Given this list of marker genes Man1c1, 1700104B16Rik, Col4a4, Ap1m1, Carmil1, Tmem95, Inafm1, Sergef, Bmf, Pcid2, Itgb8, Arhgef40, 1700003M07Rik, Gskip, Cimap3, Zfp653, Asb7, Ncoa5, Gadd45g, Cnnm2, Taf11, Fam216a, Ppp5c, Rasgrf2, Panx1, Ric8a, Tiam1, Jam3, Ift57, Matcap2, Atp6v1d, Kcp, Pdik1l, Hhipl1, Nudt1, Kif3b (kinesin family member 3B), Asic2, Ccdc138, St6gal2, Nfkbiz, Git1, Rsph4a, Gse1, Kcnmb3, Mfsd2a, Psen1, Shb, Tbc1d16, Impdh1, Lrfn4, 1700003E16Rik, Lrrc43, Cfap73, Brms1, Col26a1, Faah, Fbxo31, Ppp1r13l, Sgsm1, Spmip8, Smarcd3, Ssr2, Susd1, Dok7, Camk2a, Cldn9, 1700041G16Rik, Polr1f, Atp12a, 5033430I15Rik, Hsf1, Tm9sf1, Tsr1 (TSR1 20S rRNA accumulation), Ush2a, Trmt5, Pinlyp, Fzr1, Slc6a3, Pde6c, Snrnp25, Arhgap44, Macrod1, Efl1, Col4a6, Gm15934, Tmem88b, Scrn1, Churc1, Pcsk2os2, Rsad1, Syt5, Mir330, Eftud2, Nek2 (NCBI Gene Id 98226), AA386476, Gpbar1, Mrps2, Gpat3, 4931415C17Rik, Mms19, Pnma8a, Hrh2, Crocc2, Shank2, Gm10044, Mir6392, Mxd4, Dpp6, Sys1, Dnah7a, Pde4a, Cemip, Slc25a29, Fam167a, Inpp4a, Spata7, Togaram1, Akap9, Wdr90, Lgi4, Abr, Usp46, Gm3294, Sgms2, Sppl2b, 1500035N22Rik, Mir132, Clba1, Apbb1, Syn2, Aldh3b1, Gm11585, Tenm4, Psmc2, Padi1 (NCBI Gene Id 213073), Plek2, Slc25a10 (solute carrier family 25 (mitochondrial carrier, dicarboxylate transporter), member 10), Slc7a6, Mapre3, Pgap4, Rufy2, Gm16505, Arih1, Gm17249, Med9, Dusp6, Pdgfa, Vldlr, Dyrk3, Anks1, Cib1, Hspa4l, Med25, Gng4, Capn10, Tnfaip1, Saxo2, Pear1, Rcan3, Slc35c2, E2f7, Cerk, Iqsec1, Ubtf, Tprn (taperin), Rnf183, 9930004E17Rik, Dync2li1, 1500026H17Rik, Usp30, Abtb3, Ppie, P2rx5, Mir92b, 9130019P16Rik, Mkx, Qrich1 (glutamine-rich 1), Adgra1, Ift20, Wdr54, Trp53rkb, Zbtb16 (NCBI Gene Id 235320), Spata3, Cep135, Vgll2, Osbpl3, Tmem62, 2900072N19Rik, Wscd2, Nphs1, Aldoa, Sh3rf1, Pfkfb3, Zfta, 1700018B08Rik, Asb13, Cep128, Tango2, 1700051A21Rik, Uckl1os (uridine-cytidine kinase 1-like 1, opposite strand), Rcan1, Dennd4b, Neurl2, Ddx31 (NCBI Gene Id 227674), Gtf2e2, Prdm15, Llgl1 (LLGL1 scribble cell polarity complex component), Marchf4, Cfap144, Gm17733, 4930563E18Rik, Grk4, Ccdc33 (coiled-coil domain containing 33), Rogdi, Thrb, Gsdme, Smim1, Iqub, Gm10517 (NCBI Gene Id 669853), Atosa, Gm23205, Dusp3, Fntb, Rhpn1, Dysf, Lrba, Atxn1, Ppdpf, Spr-ps1, Dis3l2, Myl4, Suds3, Clock, Layn, Eif2s1, Gm12592, Coq3, Gm35409, Mcf2l, Nkx2-2, Mfap5, Nop14, Hycc1, Ndrg1, Cxcr4, Nherf1, Gm10425, Gprin3, Kcnt1, Rlf, Gm13067, Tagln3, Mtx1, Tekt4, Kcnb2, Cd55os, Pxn (NCBI Gene Id 19303), A230060F14Rik (NCBI Gene Id 791330), Gm16685, Slc38a6, Xaf1, Celf6, Zfp703, Kcnj9, Hcn4, Synpo, Cacfd1, Prdm4, Mfsd11, Plch2, Spon1, Map3k5, Ogfr, Pdxk, Ccdc126, Gm16083, Trak2, Tspoap1, Nipal2, Mboat7 (membrane bound O-acyltransferase domain containing 7), Dcun1d3, Dlec1, Gm42722, Tbcel, Npnt, Usp43, Dgkb, Setd7, Gm6277, Cd55 (NCBI Gene Id 13136), B3galt5, Tctn1, Slc39a6, Lyrm1, Spns1, Gm19409, Moap1, Crhr2, Kcnc4, Mir5126, Tubgcp3, Jakmip1, Rps19, Polr2b, Cul4a, Togaram2, Prr15l, Cfap97d1, Arhgap23, Gm13889, Mast3, Gdpgp1, Rcbtb2, Med9os, Ppm1d, Anapc7, Trim15, 9130017K11Rik, Ptpn13, Cnga4, Sirt1, Ppme1, Ptpn4, Dync2i2, Srsf2, Bphl, Nfil3, C2cd3, Arfip1, Wnt4, Il7, Lins1, Grk5, Prkdc, Cfap74, Uckl1, Smim29, Atp2c2, Hgs, Adm, Pin1, Rimbp2, Hmgcll1, Adgb, Rpa1, Fndc11 (fibronectin type III domain containing 11), Pik3ip1, Ptpro, Mrpl47, Zfp287, Hipk3, Akt1, Map3k21, Tns1, Entpd1, Gm10602, Galnt14, Pspc1, Cfap44, Mir378a, Gm12976, Trp53i11, 1700064M15Rik, Ift43, Dnajc12, T2, Gcc2, Kmt5c, Cilk1, Ffar4, Rpl18, Sema3f, Dyrk1a, Lyset, Gpr25, Cfap43, Apbb2, Aste1, Gm12972, Gm19744, Ccdc30, Tacr1, Gm12198, Ttyh3, Etnk2, Ripk4, Meaf6, Doc2a (double C2, alpha), Lsm7, Setd4, Rab11fip4, Ccdc88a, Adra2a, Gm13562, Sipa1l1, Arl4c, Ung, Mapk10, Lrrc36, 4930577N17Rik, Gpn3 (GPN-loop GTPase 3), Kirrel2, Nup35 (nucleoporin 35), Nsd3, Akr1e1, Fam222a (NCBI Gene Id 433940), Fbxl2 (NCBI Gene Id 72179), Krt9, Dennd2b, Gtf3c4, Fgf5, Mdga1, Nap1l1, Lrrc8b, 5530401A14Rik, Bltp3a, Gm11638, Mbp, Dlx4, Csmd2, Klf6, Tm7sf2, Gm24610, Ptbp3, Sh3rf3, Klf9, Lmna, 9530068E07Rik, Coq8b (coenzyme Q8B), Ptf1aos, Agbl5, Chd3, Ppil3, Gm4925, Rnf32, Mfsd4b1, Spock1, Stoml2, Cactin, Sgsm2, Gm12712, Ucp2, Tmem126b, Myo1b (myosin IB), Adamts20, 2310030G06Rik, Cartpt, Eogt, Rcc2, Tctn3, Ptp4a3, Dnah9, Pwwp2b, Gle1, Tfip11, Ttll10, Cd55b, Xrcc1, Gzmk, Igfbp2, Iffo2, Gm5493, Cibar2, Klhl42, Lin9, Taar4, Cog8, Tmc6, Dnttip1, Fads2, Pkp1, Fbxo7, Samd10, Rgp1, Notch1, Mdm1, Tsga10, Cage1, Sec61a1, Yod1, Gm2895, Vwa3b, Timm10, Tatdn2, Slmap, Lrrc23, Tmem121, Rasl11a, 4930558J18Rik, 1700025G04Rik, Gck, Trim2, Prrg4, Rdx, Gba2, Zbtb48, Josd2, Pltp, Lrpprc, Phyhip (NCBI Gene Id 56178), Sdk2, Dnah11, Ptpru, Sstr2, Klf13, Osgin1 (NCBI Gene Id 71839), Zfp112, Gm27198, Dnai2, Cinp, Map6, Atp6v1c2, Tecpr2, Fads6, Cenpf, Strn4, Vps51, Eif4a3, Mycbp, Tcf12, Sfxn2, 1700069B07Rik, Epb41l1, Wfdc3, Gm13490, 1700074A21Rik, Kcnh8, Fbln1, Trpm1, Myo6, Tle3, Sp3, Arl16, Drc1, Zbtb18, Eml2, Gm36017, Arl1, Plekha2, Nfatc2, Dyrk2, Cenpj, Ppp1r12b (NCBI Gene Id 98269), Cimip2c, Kif26b, Dusp5, Ngf (nerve growth factor), Ctsa, Tbpl1, Zfyve28, AI504432, Cstpp1, Gm22937, Cx3cl1, Mir6912, Pfkfb2, Rnf141, Gpr180, Gm15569, Gm12339, Reno1, Elp2, Cbfa2t3, Snapc4, Cfap298, Dalrd3, Kcnh6 (potassium voltage-gated channel, subfamily H (eag-related), member 6), Map9, Slc12a5, Ccdc28b, Sfxn5, Lrrc49 (leucine rich repeat containing 49), Spsb1, Nav2, Nif3l1, Gm12536, Abcc4, here is a description of the gene set: species: Mus musculus Genes containing one or more binding sites for (Rfx6) in their promoter regions (TSS -1000,+100 bp) as identified by GTRD version 20.06 ChIP-seq harmonization. Mouse Gene Set: RFX6_TARGET_GENES from publication Yevshin I, Sharipov R, Kolmykov S, Kondrakhin Y, Kolpakov F (PMID 30445619)